The following is a description of a gene set: Genes down-regulated in B lymphocytes: light zone versus dark zone. species: Homo sapiens from publication Victora GD, Dominguez-Sola D, Holmes AB, Deroubaix S, Dalla-Favera R, Nussenzweig MC (PMID 22740445) Human Gene Set: GSE38697_LIGHT_ZONE_VS_DARK_ZONE_BCELL_DN Microarrays of gene expression in human germinal center light zone and dark zone B cells sorted according to the expression of cell surface molecules CD83 and CXCR4 We used microarray data to identify genes differentially expressed by B cells in the light and dark zones of germinal centers from human tonsil specimens., and this is the list of marker genes: MS4A14, DMC1, CSRNP3, CBFA2T3, ARID5B, HOXB9, NPY, ITIH3, FAM167A, TIGD4, FHDC1, CALB1, TSGA10IP, MIR194-1, DYDC2, SLC7A13, CLDN18, NOX4, MEPE, KRT17, CNTN3 (NCBI Gene Id 57632), AGAP3, NAT9, BOC, NMRK2, MIR141, CDK20, DPH3P1, COLGALT2 (NCBI Gene Id 23127), MMD2, GP2, LIPT2, AMER2, FZD6, ATP6V1C2 (ATPase H+ transporting V1 subunit C2), LRGUK, B3GNT9, GLG1, TRHDE, LRRIQ3, FLACC1, FAM43A, NAT8B (NCBI Gene Id 51471), PLA2G1B (NCBI Gene Id 5319), FADS3, SDSL, NFIB, LORICRIN, IQCF3, OVOL1, CYP24A1, SLC35G1, DMKN, PRR16, MST1R, OXT, PDPN, MIR615, NR3C2, CCN1, OSCAR, B3GNT7, DLX6, SLC35F3, DNALI1, SEL1L3, C1QTNF2, PAPPA, HOXA11 (NCBI Gene Id 3207), ALK (NCBI Gene Id 238), RAB15, MIR300, OBP2B, LOXL4, PIGR, WNT1, HNF1A, RPS6KL1, DIPK1B, CHRNA5 (NCBI Gene Id 1138), CLSTN2, COLEC11, DAO, LPAR3, PLA2G10, MIR26B, REEP1, MYMK, MIR138-2, TENM2, GRIK1, SH3BP5, SLC16A9, CSNK1D, PRR15, NRK, RHOV, GALNT14 (NCBI Gene Id 79623), BPIFC, NEGR1, TNFRSF11B, CDRT4, UPP2, SPHK1, LCN12, ALDOB, IL31, SULT1E1, LPCAT1, IGSF9, COL4A2, WNT16, ANK1, SNORA3A, DKK2, MGAT3, MIR346, CD300C, CES2, PIH1D2, NEK9, ALDH1A1, SMOC1, ALPK2, SPAG17, ADAM22, IQCF1, CXXC4, PKP3, MAGIX